The following is a description of a gene set: The gene expression program underlying the specification of human cell types is of fundamental interest. The study authors generated human cell atlases of gene expression and chromatin accessibility in fetal tissues. For gene expression, the study authors applied three-level combinatorial indexing to >110 samples representing 15 organs, ultimately profiling ~4 million single cells. The study authors leveraged the literature and other atlases to identify and annotate hundreds of cell types and subtypes, both within and across tissues. Our analyses focused on organ-specific specializations of broadly distributed cell types (such as blood, endothelial, and epithelial), sites of fetal erythropoiesis (which notably included the adrenal gland), and integration with mouse developmental atlases (such as conserved specification of blood cells). These data represent a rich resource for the exploration of in vivo human gene expression in diverse tissues and cell types. studied in species Homo sapiens from publication Cao J, O'Day DR, Pliner HA, Kingsley PD, Deng M, Daza RM, Zager MA, Aldinger KA, Blecher-Gonen R, Zhang F, Spielmann M, Palis J, Doherty D, Steemers FJ, Glass IA, Trapnell C, Shendure J (PMID 33184181) Marker genes curated from the annotated cluster as represented in the Descartes Human Gene Expression During Development database. Human Gene Set: DESCARTES_FETAL_INTESTINE_ERYTHROBLASTS, and this is the list of marker genes: OR2W3, IGF2BP2-AS1, UBAC1, SLC2A1, FECH, SLC14A1, TSPAN32, RNF123, TMCC2, FLACC1, DCK, TFR2, C17orf99, ISCA1, SLC2A1-DT (NCBI Gene Id 440584), KLF1, DMTN, SLC1A5, HEMGN, TRIM58, ABCC13, UROS, PRDX2, H1-2 (NCBI Gene Id 3006), RILP, FAM83D, LINC02506, SMIM1, ARRDC2, SLC22A4, GATA1, GPLD1, FAM210B, GYPB, GYPE, CTB-30L5.1, EPOR, TUBB1, RHCE, CR1L, ALAD, AMMECR1, TBCEL (NCBI Gene Id 219899), ZNF451, HBE1, MOB1B, MOSPD1, SLC25A37, ATG14, CMAS, SEC62-AS1, LINC01134, HBG2, RFESD, SGMS1, SPECC1, C9orf153, PPME1, OSBP2, YPEL4, BCL2L1, UROD, TMOD1, EIF5AP2, MYL4, ANKLE1, ANKRD18B, EPB41, RBM38 (NCBI Gene Id 55544), HBG1, LNCRNA-IUR, TCP11L2, HTRA2, SLC22A16, FAM117A, TLCD4, TLCD4-RWDD3, TDH, CYP3A4, PPOX (NCBI Gene Id 7440), AHSP, HBM, RHAG, PDCD10, SNCA, UBE2O, CPEB4, GBGT1, GMPR, HBZ, EIF2AK1, DYRK3, SPTA1, E2F2, RNF224, PIM1, MED8, GLRX5, GPR146, ENSG00000260592, TRAK2, TSPO2, SNX22, RGS6, CCDC144CP, HBB, HBA2 (NCBI Gene Id 3040), TSPAN5, SLC25A21, UBR2, SLC25A39, ATG4D, DCAF12, HBA1, RHD, RNU6-890P, EPB42, SLC4A1, XK, CPOX, ALAS2, PHOSPHO1, PIGQ, CD46P1, SELENBP1, NFE2, ART4, ANKRD9, HECTD4, ERMAP (erythroblast membrane associated protein (Scianna blood group)), RSAD2, KCNN4, YOD1, NCEH1, SLC6A9, BPGM, TANGO2, GYPA, NPL, RIPOR3, ATOSB, ANK1 (NCBI Gene Id 286), TAL1, BLVRB, HMBS, SPTB, CAT, TRIM10, ACSL6, DHRS13, SEC14L4, ABCB6, CHST2, TTPAL, GFI1B, MYO18B, STRADB, ST6GALNAC4, FOXO4, MFSD2B, XPO7, NHLRC4